Given this list of marker genes GNRH1, IHH, ERBB2, TMEM131L, CLEC4G, BMP4, CDKN2A, here is a description of the gene set: Human Gene Set: GOBP_NEGATIVE_REGULATION_OF_IMMATURE_T_CELL_PROLIFERATION species: Homo sapiens Any process that stops, prevents, or reduces the frequency, rate or extent of immature T cell proliferation.